Given this list of marker genes RICTOR, TUBA1A, GRAMD1A, FCMR, LSP1, TNFRSF13C, FLNB, RASGRP3 (NCBI Gene Id 25780), STAP1, CHST15, POLD1, CARD6, SNX9, MYH9, GABRA2, ID1, RFC1, LGALS3, EGR1, LRIG2, SPSB4, SAMHD1, RRM2B, DENND5B, ADD1, CORO1A, CD200, CHCHD10, IL21R, BTLA, RAD21, TNIK, SNX2, PGAP1, C1GALT1, PDE2A, SORL1, SNORD35B, RETNLB, FLI1, MEF2C, B3GNT5, PLEKHO1, FGD3, LBH, PXK, CACNA1I, SLAMF1, ID3, RNF38, IRF2, TRIM59, LMBRD1, PTMA, CMAHP, ARHGEF18, ADAMTS6, ARHGEF3, DGKA, CITED2, LMO2, ISG15, RHOH, CRIP3, ADD3, KDM7A, GIMAP4, BCL6, ENPP1, ATP1B1, SMAP2, RASGRP2, NCOA1 (nuclear receptor coactivator 1), TBC1D1, MYADM, SCML4, DOCK11, MSN, MYO1G, SATB1, FCHSD2, RAPGEF6, CC2D2B, RIPOR2, SMC3, DGKD, CCR6, JAK1, ATP6V0A1, CXCR4, CSNK1G3, SSPN, GGA2, SH3BP2, SELE, KIF21B, CIB4, DMXL1, PRLR, ARID1A, RNF122, NRM, PKP3, GMFG, SNX29, CD55, IYD, ITGB7, SBK1, RFK, NDC80, S100A10, WASF2, SMARCC2, ABCA1, KLF2, BRWD1, TEC, PSD3, CCND3, PPP3CA, PICALM, ZNF318, GIMAP3P, ZAR1L, ANKRD44, AHNAK, CD69, CUX1, AFF3, BIN2, LCP1, ALCAM, CTSH, FOXO1, MED13, RNF144A, CERK (ceramide kinase), CRISP3, TRIB2, ANKRD13D, TRIM25, MECP2, VIM, IQGAP1, ARHGAP45, MAP4K4 (mitogen-activated protein kinase kinase kinase kinase 4), STAT4, GATAD2B, KLF6, DCLK2, AIDA, BACH2, SGK1, SLC9C1, EMP3, HORMAD1, LRP12, FLNA (filamin A), TMSB10, NSMCE1, SMC5, SH3BP5, CDK19, SSBP2 (single stranded DNA binding protein 2), H3-3A, PTK2B, ST6GAL1, MBLAC2, PARP1, SELL, CIITA, NEURL3, BET1L, ABCD4, RASA3, AKNA, TGFB1, FRY, DYRK2, DNAJC9, AP1M1, FMNL1, here is a description of the gene set: Human Gene Set: GSE26488_CTRL_VS_PEPTIDE_INJECTION_OT2_THYMOCYTE_DN studied in species Homo sapiens from publication Kasler HG, Young BD, Mottet D, Lim HW, Collins AM, Olson EN, Verdin E (PMID 21398603) Genes down-regulated in double positive thymocytes from OT-2 transgenic mice: control versus injected with agonist peptide. Abstract of publicaton: CD4/CD8 double-positive (DP) thymocytes express the transcriptional repressor Histone Deacetylase 7 (HDAC7), a class IIa HDAC that is exported from the cell nucleus after T cell receptor (TCR) engagement. Through signal-dependent nuclear export, class IIa HDACs such as HDAC7 mediate signal-dependent changes in gene expression that are important to developmental fate decisions in multiple tissues. We report that HDAC7 is exported from the cell nucleus during positive selection in thymocytes, and regulates genes mediating the coupling between TCR engagement and downstream events that determine cell survival. Thymocytes lacking HDAC7 are inefficiently positively selected due to a severely shortened lifespan and exhibit a truncated repertoire of TCR Jalpha segments. The expression of multiple important mediators and modulators of the response to TCR engagement is altered in HDAC7-deficient thymocytes, resulting in increased tonic MAP kinase activity that contributes to the observed loss of viability. Remarkably, the activity of Protein Kinase D, the kinase that mediates nuclear export of HDAC7 in response to TCR signaling, is also increased in HDAC7-deficient thymocytes, suggesting that HDAC7 nuclear export governs a self-sustaining auto-excitatory loop. These experiments add to the understanding of the life/death decision in thymic T cell development, define a novel function for class IIa HDACs, and point to a novel feed-forward mechanism whereby these molecules regulate their own state and mediate stable developmental transitions. Title of manuscript: Nuclear Export of Histone Deacetylase 7 During Thymic Selection Mediates Immune Self-tolerance. abstract of manuscript: Histone Deacetylase 7 (HDAC7) is a TCR signal-dependent regulator of differentiation that is highly expressed in CD4/CD8 double-positive (DP) thymocytes. Here we examine the effect of blocking TCR-dependent nuclear export of HDAC7 during thymic selection, through expression of a signal-resistant mutant of HDAC7 (HDAC7-delta-P) in thymocytes. We find that HDAC7-delta-P Transgenic thymocytes exhibit a profound block in negative thymic selection, but can still undergo positive selection, resulting in the escape of autoreactive T cells into the periphery. Gene expression profiling reveals a comprehensive suppression of the negative selection-associated gene expression program in DP thymocytes, associated with a defect in the activation of MAP kinase pathways by TCR signals. The consequence of this block in vivo is a lethal autoimmune syndrome involving the exocrine pancreas and other abdominal organs. These experiments establish a novel molecular model of autoimmunity and cast new light on the relationship between thymic selection and immune self-tolerance. Goal of Microarray experiment: We did these experiments to determine how alteration of the function of HDAC7, a site-specific and signal-dependent repressor of transcription, changes gene expression in CD4/CD8 DP thymocytes.